The following is a description of a gene set: from publication Kyng KJ, May A, Stevnsner T, Becker KG, Kølvrå S, Bohr VA (PMID 15897889) Human Gene Set: KYNG_DNA_DAMAGE_BY_GAMMA_AND_UV_RADIATION species: Homo sapiens The accumulation of DNA damage and mutations is considered a major cause of cancer and aging. While it is known that DNA damage can affect changes in gene expression, transcriptional regulation after DNA damage is poorly understood. We characterized the expression of genes in human primary fibroblasts after exposure to three different kinds of cellular stress that introduces DNA damage: 4-nitroquinoline-1-oxide (4NQO), gamma-irradiation, or UV-irradiation. Each type of stress elicited damage specific gene expression changes of up to 10-fold. A total of genes had similar changes in expression of 3-40-fold after all three kinds of stress. We examined transcription in cells from young and old individuals and from patients with Werner syndrome (WS), a segmental progeroid condition with a high incidence of cancer, and found various age-associated transcriptional changes depending upon the type of cellular stress. Compared to young individuals, both WS and old individuals had similarly aberrant transcriptional responses to gamma- and UV-irradiation, suggesting a role for Werner protein in stress-induced gene expression. Our results suggest that aberrant DNA damage-induced gene regulation may contribute to the aging process and the premature aging in WS Gamma and UV responding genes., and this is the list of marker genes: N4BP1, CCNC, PPP3CA, SLC6A1, RPS6KB1, DNAJA1, ENPP5, NDUFB6, ITIH2 (NCBI Gene Id 3698), COPB2, AHCY, APBA3, ATP6V0A1, CDCA7, RBBP6, CCNA2, SLC1A3, VCAM1, GADD45A, ENTPD1, ENDOU, PSG2, CCL28, SAA1, NRP2, PBX1, DNALI1, MMP7, MORF4L1, HPCA, CCND1, ERCC5, SEMA7A, FMO4, PRKD2, GCLC, EVI2A, COG6, CCNH, ACTN4, SIAH1, IL10RB (interleukin 10 receptor subunit beta), NNMT, ITPKB, PLD6, SERPINB6, RBL1, ADSL, HEXB, IGFBP1, C1QTNF6, CXADR, CRHBP, PTGER4, CXCR4, LDHD, TPM1, H2AJ, PLCL1 (phospholipase C like 1 (inactive)), PRLR, PPP1R14A, LOX, PHF3, RAB6A, PTH, CSNK1A1, EML4, SEM1, MSX2, BCL2L2, ALDH9A1, GYPB, CREBBP, DIS3, MEF2C, RPS6KA3, POLR2A